Given this list of marker genes CREB3, AGTR1, CREB3L1 (cAMP responsive element binding protein 3 like 1), CREB3L3, PLCB2, PLCB4, ATF4, CALM2, CAMK2G, PLCB3 (NCBI Gene Id 5331), GNAQ, CREB3L4, CAMK1, CREB3L2, CAMK1D, PLCB1, CAMK2D, CAMK2B, CALM3, CAMK1G, CYP11B2, ATF2, ATF6B, CREB1, CAMK4, CREB5, CALM1, CAMK2A, here is a description of the gene set: Angiotensin-aldosterone signaling pathway. Pathway ID: N00301. Pathway type: Reference. Pathway class: nt06316 Renin-angiotensin-aldosterone signaling. Human Gene Set: KEGG_MEDICUS_REFERENCE_ANGIOTENSIN_ALDOSTERONE_SIGNALING_PATHWAY species: Homo sapiens Pathway Definition from KEGG: AngII -> AGTR1 -> GNAQ -> PLCB -> IP3 -> Ca2+ -> CALM -> CAMK -> CREB => CYP11B2 -> Aldosterone